Given this list of marker genes Atp13a2 (ATPase type 13A2), Rab24, Ubqln2, Becn1, Calcoco2, Atg9a, Atg13, Irgm2, Ulk3, Sqstm1, Tecpr1, Atp6ap2, Trp53inp1 (transformation related protein 53 inducible nuclear protein 1), Atg16l1, Ftl1, Gabarap, Tmem150b, Chmp5, Entpd4b, Cln3, Stx17, Rab7, Fyco1, Wipi2, Ambra1, Ulk1, Rufy4, Wipi1, Hap1, Trim21, Rab12, Rpn2, Vps11, Vmp1, Fth1, Washc1, Pik3c3, Htt, Vps33a, Tbc1d17, Srpx, Map1lc3b, Hspa8, Vps18, Vps16, Nrbf2, Atg16l2, Chmp2a, Map1lc3a, Jmy, Vti1a, Irgm1, Snap29, Igtp, Mcoln3, Pip4k2b, Atg9b, Lamp1, Aup1, Sting1, Lamp2, Chmp2b, Ubqln1, Irgq, Tax1bp1, Rab23 (NCBI Gene Id 98704), Ubqln4, Peg3 (NCBI Gene Id 353312), Mapk15, C9orf72, Chmp6, Atg14 (autophagy related 14), Tbc1d12, Chmp1b2, Wdfy3, Dapk2, Zfyve1, Trim32, Rb1cc1, Atg4b, Nbr1, Gabarapl1, Chmp1a, Tbc1d14, Ulk2, Chmp4c, Chmp1b, Tm9sf1, Optn, Rubcnl (RUN and cysteine rich domain containing beclin 1 interacting protein like), Mefv, Tmem74, Ticam1, Tbc1d5, Tbc1d25, Gabarapl2, Wdr81 (NCBI Gene Id 192652), Entpd4, Tex264, Uvrag, Sh3glb1, Pip4k2c, Prkd1, Atg12, Rab2a, Pik3r4, Chmp7, Rab3gap2, Tmem230, Trp53inp2, Atg5, Rab2b, Chmp4b, Gramd1a, Lrrk2 (NCBI Gene Id 79409), Pip4k2a, Chmp3, Osbpl7, here is a description of the gene set: A double-membrane-bounded compartment that engulfs endogenous cellular material as well as invading microorganisms to target them to the lytic vacuole/lysosome for degradation as part of macroautophagy. species: Mus musculus Mouse Gene Set: GOCC_AUTOPHAGOSOME